Given this list of marker genes ZNF131, EIF3J, NUS1, SYCP2, RBM18, ZNF615, B3GNTL1, CDC14A, UACA, GRID2, PSIP1, FAM199X, PIK3C2B, ABCD3, TCF12, ATXN1, INTU (NCBI Gene Id 27152), ZNF233, FRAS1, SNX16, ZBTB10, CHP1, MSL1 (MSL complex subunit 1), RASSF9, BCL11A, KBTBD8, STAT3, CD28, CSTF1, ZNF441, FSD1L, FXR1, SLC44A1, ZC3H12C, ANP32E, USP15, ARL6IP5, RIMKLB, NTS, FAM76B, IARS2, LMTK2 (lemur tyrosine kinase 2), GOPC, JAKMIP2, PML, ZNF704, CPEB3, TYW3, TET2, ING3 (inhibitor of growth family member 3), C2CD6, NAA25 (N-alpha-acetyltransferase 25, NatB auxiliary subunit), ZNF37A, SERPINE1, KLHL28, NAP1L1, SEPHS1, TMEM192, THAP2 (THAP domain containing 2), POU2F1, ASAP1, C5orf22, UBN1, SLC4A7, ITPR2, FRAT1, NBN, SRP72, VCF1, TANK, ODAD4, CCDC88A, IL13RA1, PIK3CB, RNF222, WDR26, ELMOD2, PELO, PPIP5K2, POU4F2, KMT2A, HOOK3, SYNPR, GPATCH8, ZBTB25, PLXDC1, LDLRAD3, ERBIN, GPATCH2L, VWA8, RPS6KA3, ELF1, C9orf152, GSTCD, USP49, NFATC3, C2CD2, SORCS1, TMEM74, TGFBR2, CEP41, ARID4A, RBM41, SLITRK4, CA13 (carbonic anhydrase 13), TTC13 (tetratricopeptide repeat domain 13), DNAJC25, MAP1LC3B, PTEN, ZNF624, TSEN2, SCOC, JAK2, RARRES1, APP, PTPRN2, NTNG1, PCDH18, SENP6, RSAD1, here is a description of the gene set: studied in species Homo sapiens Human Gene Set: MIR337_3P Genes predicted to be targets of miRBase v22 microRNA hsa-miR-337-3p in miRDB v6.0 with MirTarget v4 prediction scores > 80 (high confidence targets). from publication Chen Y, Wang X (PMID 31504780)